Given this list of marker genes Cyfip1, Ulk2, Anapc2, Nkx6-1, Mt3, Ryk, Trpv2, Map1b, Abl1, Clasp2, Sin3a, Disc1, Vegfa, D130043K22Rik (NCBI Gene Id 78157), Olfm1, Rtn4r, Bcl11a, Cxcl12, Slit1, Shtn1, L1cam, Gsk3b, Rnf6, Plxna3, Apoe, Slit2, Mgll, Sema6c, Omg, Ptprs, Map2, Pou4f2, Rufy3, Rgma, Cdk5, Limk1, Trpc5, Sema3g, Smurf1, Trim46 (tripartite motif-containing 46), Ttc3, Wdr36, Myo5b, Cdkl5, Tnr, Ilk, Ifrd1, Dip2b, Cdh1 (NCBI Gene Id 12550), Adcy10, Ccr5, Ndel1, Wnt3, Dcx, Ngf, Sema6d, Nrp1, Sema4f, Sema3a, Fxn, Golga4, Actr3, Wnt5a, Plxna4, Fgf13, Megf8, Lrp1, Gdi1, Ep300, Macf1, Adnp, Ntrk3, Crabp2, Rab21, Hdac6, Arhgap4, Mag, Ntn1, Barhl2, Pafah1b1, Wnt3a, Rpl4, Dbnl, Sema5a, Sema3f, Lpar3, Bdnf (NCBI Gene Id 12064), Fstl4, Mapt, Dbn1, Ist1, Efna5, Srf, Cttn, Dnm2, Bmpr2, Dscam, Twf2, Rnd2, Sema7a, Pum2, Epha7, Ulk1, Eif4g2, Map3k13, Rtn4, Fn1, Spart, Ttl, Cdkl3, Eif2b2, Cdh4, Zfyve27, Arhgap32, Pak1, Sema4d, Draxin, Islr2, Tnfrsf12a, here is a description of the gene set: Any process that modulates the extent of cell growth. Mouse Gene Set: GOBP_REGULATION_OF_EXTENT_OF_CELL_GROWTH studied in species Mus musculus